The following is a description of a gene set: species: Homo sapiens Catalysis of the reaction: acetyl phosphate + L-lysine = phosphate + N6-acetyl-L-lysine. Human Gene Set: GOMF_L_LYSINE_N_ACETYLTRANSFERASE_ACTIVITY_ACTING_ON_ACETYL_PHOSPHATE_AS_DONOR, and this is the list of marker genes: NAT8, EP300, NAT8B, ATAT1, KAT2B, ESCO2